The following is a description of a gene set: studied in species Homo sapiens Isoenergetic transfer of ubiquitin from one protein to an existing ubiquitin chain via the reaction X-ubiquitin + Y-ubiquitin = Y-ubiquitin-ubiquitin + X, where both the X-ubiquitin and Y-ubiquitin-ubiquitin linkages are thioester bonds between the C-terminal glycine of ubiquitin and a sulfhydryl side group of a cysteine residue. Human Gene Set: GOMF_UBIQUITIN_UBIQUITIN_LIGASE_ACTIVITY, and this is the list of marker genes: ANAPC11, UBR5, HUWE1, UBE2K, PELI2, PRPF19, PPIL2, TRAF6, STUB1, UBOX5, UBE4A, RBX1, AMFR, UBE4B, ITCH, PELI1